The following is a description of a gene set: The component of the synaptic membrane consisting of gene products and protein complexes that are loosely bound to one of its surfaces, but not integrated into the hydrophobic region. studied in species Homo sapiens Human Gene Set: GOCC_EXTRINSIC_COMPONENT_OF_SYNAPTIC_MEMBRANE, and this is the list of marker genes: C1QA, PPP1R9B, AP2B1, CTNNA2, SNAP91, VWC2, PICALM, FARP1, RNF10, C1QC, CNKSR2, CRKL, FBXO2, DNAJC6, SCRIB (scribble planar cell polarity protein), STXBP1, AKAP9, SARM1, AP2M1, FGF22